The following is a description of a gene set: Genes down-regulated in I/11 erythroblast cells upon expression of an activated form of FOXO3. species: Mus musculus Mouse Gene Set: BAKKER_FOXO3_TARGETS_DN The cooperation of stem cell factor (SCF) and erythropoietin (Epo) is required to induce renewal divisions in erythroid progenitors, whereas differentiation to mature erythrocytes requires the presence of Epo only. Epo and SCF activate common signaling pathways such as the activation of protein kinase B (PKB) and the subsequent phosphorylation and inactivation of Foxo3a. In contrast, only Epo activates Stat5. Both Foxo3a and Stat5 promote erythroid differentiation. To understand the interplay of SCF and Epo in maintaining the balance between renewal and differentiation during erythroid development, we investigated differential Foxo3a target regulation by Epo and SCF. Expression profiling revealed that a subset of Foxo3a targets was not inhibited but was activated by Epo. One of these genes was Cited2. Transcriptional control of Epo/Foxo3a-induced Cited2 was studied and compared with that of the Epo-repressed Foxo3a target Btg1. We show that in response to Epo, the allegedly growth-inhibitory factor Foxo3a associates with the allegedly growth-stimulatory factor Stat5 in the nucleus, which is required for Epo-induced Cited2 expression. In contrast, Btg1 expression is controlled by the cooperation of Foxo3a with cyclic AMP- and Jun kinase-dependent Creb family members. Thus, Foxo3a not only is an effector of PKB but also integrates distinct signals to regulate gene expression in erythropoiesis. from publication Bakker WJ, van Dijk TB, Parren-van Amelsvoort M, Kolbus A, Yamamoto K, Steinlein P, Verhaak RG, Mak TW, Beug H, Löwenberg B, von Lindern M (PMID 17353275), and this is the list of marker genes: Tex22, 2310057M21Rik, Wdr74, Ccs, Smc2os, Fbxo2, Mmp24os1, Mab21l2, Adgrg5, Lemd2, Zfp358, Prkag1, Nat8f1, Ppp1r1a, Gfer, Cdh16, Glod4, Ciart, Cyth2, Strap, Tbp, Arhgap23, Prcc, Hmgn1, Agpat5, Timm10, Slc22a2, Nudt16l2, Mex3c, Yipf6, Cby2, Tubb5, Dmpk, Gnmt, Dynlt4, Cenatac, Ifi35, Slc20a1, Por, Calu, Fzd8, Arf3 (NCBI Gene Id 78763), Exd2 (NCBI Gene Id 97827), Tshz2, Cxcl14, Rpp21, Ptpre, Pcyt2, Zfp811, Lsm10, Fzd10, Mapkapk3, Slc9a8, Dcp2, Hoxd10, Slpi, Zdhhc16 (NCBI Gene Id 74168), Nrp1, Cops7a, Wdr4, Akr1cl, Tpgs1, Sys1, Cox8a, Mki67, N4bp2l2, Cyp2j6, Tnrc18, Fam136a, Snrpa, Klhl22, Zfp524, Chn1, Prrt2, Mmut, Cobl, Cops8, Pop5, Mexis, Psma1, Nkd1 (naked cuticle 1), Focad, Strn3, Pafah1b2, Msc, Ank1, Zfp292, Pfkfb3, Dapp1, Diras2, Hgh1, Pnck, Spef2, Polb, Mideas, Tulp3 (TUB like protein 3), Prr32, Tacstd2, Rnaseh2a, Adgrg1, Ighg3, Srsf4, Fibin, Desi1, Zfp653, Med10, Mrps26, Ucma, Acad10, Qpctl, Dgcr6, Fbxo45, Vipr2, Scrib, Cfd, Utp6, Anks4b, Arhgef17, Ltn1, Clint1, Tceal9, Thumpd1, Rcor1, Sec61b, Gprin1, T, Btbd9, Pdlim7, Mtfp1, Bcl11a, Etv5, Deaf1, Cth, Bckdha, Rassf6, Pole3, Cdk2, Slc19a1, Aprt, Rab28, Bmp5, Rnaseh2c, Clec2l, Sel1l, Hic2, Gykl1, Srsf2, P2rx1, Wbp1, Trim27, Ndufb10, Smc3, Hspb8, Dmrtc1a, Mgp, Skil, Tcf7l1, Pnoc, Lrrc42, Pcbp4, Chst15, Cav2, Capn15, Nelfa, Fcrla, Ccdc65, Alkbh7, Rdh7, Spata33, Kcnj16, Ddx18, Glrx5, Otof, Ankzf1, Soat1, Tlr1, Vps51, Slitrk1, Cetn2, Ropn1